The following is a description of a gene set: The biological process whose specific outcome is the progression of a bronchiole from an initial condition to its mature state. This process begins with the formation of the bronchiole and ends with the mature structure. A bronchiole is the first airway branch that no longer contains cartilage; it is a branch of the bronchi. studied in species Homo sapiens Human Gene Set: GOBP_BRONCHIOLE_DEVELOPMENT, and this is the list of marker genes: ITGB6, HOXA5, MMP12, TGFB1, FGF10, TCF21